Given this list of marker genes Cacna1c, Rpl26, Slc24a4, Zranb3, Ercc6, Ckap5, Pmaip1, Lrrn4, Mecp2, Kdm1a, Gja10, Slc1a2, Nscme3l, Pparg (peroxisome proliferator activated receptor gamma), Opn4, Kmt2a, Ep300, Mapk11, Prph2, Nsmce3, Bcl2, Akt1, Sema5b, Tipin, Cngb1, Eif2ak4, Msh6, Sdf4, Ercc5, Hyal3, Gpr52, Pml, Ino80, Cops9, Ddb1, Pnpla2, Lrit3, Sirt1, Rbm4, Rpe65, Nedd4, Ift20, Mapk8, Cdkn1a, Pde6c, Ap1s2, Pola1, Drd1, Per1, Men1, Atp1a2, Rad23b, Rrh, Casp7, Ppp1cc, Dynlrb1, Grk1, Lrit1, Nptn, Polh, Hmgcr, Prkaa1, Id2, Opn1mw, Adra1b, Opn1sw, Nfatc4, Cry1, Aanat, Syngap1, Deaf1, Cck, Parp1, Cdkn2d, Ddb2, Ext1, Kcne1, Atxn1, Comt, Mdm2, Crb1, Usp28, Mmp9, Fbxl21, Kras, App, Gpx1, Ppid, Dcdc2a, Ro60, Trex1, Rgs9bp, Guca1a, Slc4a10, Pbk (NCBI Gene Id 66470), Pold1, Best1, Cryaa, Timp1, Elane, mt-Nd3, Ddhd2, Mapk10, Kcnc2, Ndrg4, Ei24, Prkcd, Stk11, Arrb1, Meis2, Th, Pclaf, Ghrl, Tanc1, Ercc3, Triap1, Actr5, Slc7a11 (solute carrier family 7 (cationic amino acid transporter, y+ system), member 11), Uvssa, Pold3, Ppp1ca, Mfap4, Egfr (NCBI Gene Id 13649), Opn5, Gngt1, Ccnd1, Zzef1, Tmem161a, Synpo, Trp53inp1, Rpgr, Rhbdd1, Atoh7, Bcl3, Map3k4, Hyal2, Nr2f6, Pln, Rag1, Usf1, Drd5, Ercc1, Fbxw7, Ctns, Trpm1, Abl2, Mc1r, Kcnc1, Atr, Rp1, Trp53i13, Tuba1a, Gpr179, Ogg1, Il12a (NCBI Gene Id 16159), Mapk13, B3gat1, Ercc4, Mmp1b, Crip1, Chrnb2, Polk, Crhr1, Nlgn3, Rgr, Drd2, Cul4a, Rhno1 (RAD9-HUS1-RAD1 interacting nuclear orphan 1), Pde6b, Rbx1-ps, Usp1, Asic2, Cat, Cds2, Pcare, Cdc25a, Gnat1, Elk1, Rnf168, Ttc36, Fech, Pde6d, Per2, Sik1, Casp3, Rho, Rdh13, Ccdc66, Ppp1r1b, Myo15a, Dbh, Idua, Abcc8, Grm6, Ptprk (protein tyrosine phosphatase receptor type K), Rev1, Fos, Aqp1, Crebbp, Akt2, Cry2, Rgs14, Per3, Kit, Gnat3, Aipl1, Brsk1, Pianp, Nog, Abca7, Cers1, Slc1a3, Gnat2 (NCBI Gene Id 99904), Grin2a, Irx6, Ercc2, Gucy2f, Xpa, Rgs9 (regulator of G-protein signaling 9), Cirbp, Dct, Cdk5, Dcun1d3, Reep6, Atp8a2, Pik3r1, Ercc8, Frmpd1, Pcp2, Scn11a, Hoxa1, Yy1, Mta1, Cntnap2, Pierce1, Il12b, Ppp1cb, Rad23a, Bbs10, Col6a1, Guca1b, Tafa2, Chrd, Pde1b, Drd3, Map2k7, Bhlhe40, Adam2, Ube4b (NCBI Gene Id 80643), Zbtb1, Mme, N4bp1, Gpsm2, Casp9, Cacna1e, Nlrp1b, Cacnb4, Hrh1, Npm1, Opn3, Trim32, Dhx36, Nts, Aurkb, Asns, Hyal1, Uaca, Gpr88, Rbx1 (NCBI Gene Id 80401), Ube2a, Grin1, Braf, Primpol, Tyr, Mtor, Poli, Tulp1, Ivl, Agap3, Agrp (agouti related neuropeptide), Rela, Col6a2, Sct, Hif1a, B4galt2, Mettl3, Gh, Cacna2d4, H2ac25, Rpain, Large1, Ube2b, Gnb1, Cpt1b, Ttr, Msh2, Bmf, Mapk9 (NCBI Gene Id 26420), Itgb1, Crtc1 (CREB regulated transcription coactivator 1), Htt, Pde8b, Ccar2, Map3k20, Ddias, Usp2, Ruvbl2, Trp53, Eif2s1, Cul4b, Mapk14, Cep250, Neto1, Atp1a3, Mmp3, Gnb5, Sgk1, Map4k3, Mmp2, Rom1, Bak1, Foxb1, Pcna, Dtl, D7Ertd443e, Pias1, Bax, Sde2, Nf1, Hrh2, Nps, Cabp4, Creb1, Sema5a, Ric8a, Sirt6, Rcvrn, Brca2, Fbxl3, Nlrp1a, Cacna1f, Wrn, Col6a3 (NCBI Gene Id 98389), Hus1, Noc2l, Rbp4, Hmgn1, Mmp1a, Rad18, Smpd1 (NCBI Gene Id 20597), Rbm4b, Xpc, Sprtn, here is a description of the gene set: Mouse Gene Set: GOBP_RESPONSE_TO_LIGHT_STIMULUS Any process that results in a change in state or activity of a cell or an organism (in terms of movement, secretion, enzyme production, gene expression, etc.) as a result of a light stimulus, electromagnetic radiation of wavelengths classified as infrared, visible or ultraviolet light. studied in species Mus musculus